The following is a description of a gene set: Human Gene Set: STAT1_02 Genes having at least one occurrence of the motif CANTTCCS in the regions spanning 4 kb centered on their transcription starting sites. This matches the STAT1 transcription factor binding site V$STAT1_02 (v7.4 TRANSFAC). studied in species Homo sapiens, and this is the list of marker genes: FEM1A, CCR4, DCAF1, HMBOX1, SRSF2, CALHM1, CSRNP2, ARPC1B, OR1A1, INTS3 (NCBI Gene Id 65123), TMCO1, ZAP70, AKIRIN2, VPS41, CRK, MPI, STX6, LINC00474, CHRM1, CCND1, UQCRH, H1-0, ZNF189, STX16, SYMPK, C4BPA, ZNF570, HNRNPA2B1, EPHA1, SHC1, HOXB2, CCNI, UHMK1, PIK3CD, ARHGEF15, RGS17, ELAVL2, MRPL34, PRPF19, GDF7, ZNF385A (zinc finger protein 385A), STC1, ZNF471, HSD17B4, IKZF4, VAX1, MINDY1, PI4KB, LINC00955, FOXG1, ZMPSTE24, ADAM22, CSNK1A1, ZNF420, CS, ENOX2, USF1, IL23A, RCOR2, METTL25B, GSPT1, TXNDC12, GFI1, VGF, ZNFX1, DNAJC5G, LRFN4, PDE4D, DDX25, LRRC41, SLITRK3, LYSMD1, RAB8B, ZNF568, ZNF582 (zinc finger protein 582), NOC2L, SET, SEMA4B, GABRA1, HSPE1, RAB2A, EP300, GATA3, GRIA1, RNF220, ISG20L2, CD9, NDP, HOXC4, CNTN6, NXPH4, PAX6 (NCBI Gene Id 5080), SCNM1, SIKE1, NASP, PSMC3 (proteasome 26S subunit, ATPase 3), AMTN, PLAC1, MTF1, AGL (amylo-alpha-1, 6-glucosidase, 4-alpha-glucanotransferase), IFTAP, SH2B3, EIF2B4, GPATCH2L, SKA2, WWOX, BABAM1, POLR1B, HNRNPK, SMPD3, LIX1, MYH10, APBA3, UFC1, GLA (galactosidase alpha), MAP3K8, MTFR1L, ERG, DDOST, BCLAF1, NR6A1 (nuclear receptor subfamily 6 group A member 1), CPT2, DLX1, ITPKC, TMEM187, HNRNPH2, ARHGAP9, NUDCD1, SDHC, UBE2N, CAP1, MEX3B, KLK9, CTDSPL2, PRAF2, PCED1B, RPL28, NMNAT1, HSPD1, HDAC9, MARS1, PRKACB, ZSCAN20, SNX9, FBRS, SPTLC2, SKP2, ARMCX6, NRAS, ZRANB2, INTS9, POC1A, SYNE1, BDNF, DNAJA2, GSK3A, SLC9A1, NSD3, DRC7, PRTN3, TJAP1, SOX4, JADE2, E2F3, TLK2, ZFP2, UBR4, ZNF546, NRGN, GFUS, PYY, FTSJ1, SEC14L2, EIF2S3, CKS1B, PREPL (prolyl endopeptidase like), MICOS13, DDX47, PIGC, PDE6D, CAMKMT, PUS3, EPHB2 (NCBI Gene Id 50980), CNKSR2, FAM20B, HHEX, SF3B4, MRPL54, TMED5, UBL3, ERF, ADAP2, ODF1, MID2, PRKACA, RMI1, COX8A, LZIC, PCDHGB5, MON1A, GABPB2, GRIN2B, TIMM17A, RDH11, SRSF4, LIN28A, COQ8B, PRR11, EXTL3, ZNF571, PPP2CB, SZT2, NUCB1, SREK1, ENTR1, FBXO11, TTC1, HIVEP3, NKX2-8, MORF4L2, ALKBH8, LRP5, TCERG1, SNX17, SLC30A3, DHH, PLPP7, MRPL50, RELA, PATJ, POGZ, PCF11, FOXA3, PABPN1, EIF4G1, BET1 (Bet1 golgi vesicular membrane trafficking protein), CTTNBP2NL, HSD11B1L, SHKBP1 (NCBI Gene Id 92799), NTRK3, HOXB6, DTX2, CBX3, CAB39, PPP2R2C (protein phosphatase 2 regulatory subunit Bgamma), DDA1, CHMP2A, ZNF569, GNAI3, WBP1L (NCBI Gene Id 54909), CDK6, KLHL17, COX7B, VEZF1, MED15, DLL1, CASK, GNL2, ZBTB41, AJUBA, PCYT2 (phosphate cytidylyltransferase 2, ethanolamine), ITM2C, PRPF38B